Given this list of marker genes PINK1, UBE2S, TRIM32, AMBRA1, UBE2C, RNF135, UBE2K, TRIM6, PRKN, here is a description of the gene set: Human Gene Set: GOBP_FREE_UBIQUITIN_CHAIN_POLYMERIZATION species: Homo sapiens The process of creating free ubiquitin chains, compounds composed of a large number of ubiquitin monomers. These chains are not conjugated to a protein.